Given this list of marker genes SLC8A3, PMPCA, MAIP1, PHB2, MICU3, VDAC3, YME1L1, AKAP1, MICU2, PMPCB, VDAC2, MCUB, SMDT1, STOML2 (NCBI Gene Id 30968), MICU1, MCU, SLC8B1 (NCBI Gene Id 80024), PHB1, VDAC1, PARL, SPG7, AFG3L2, LETM1, here is a description of the gene set: Mitochondrial calcium ion transport studied in species Homo sapiens Human Gene Set: REACTOME_MITOCHONDRIAL_CALCIUM_ION_TRANSPORT